The following is a description of a gene set: Human Gene Set: GOBP_NEGATIVE_REGULATION_OF_FAT_CELL_DIFFERENTIATION studied in species Homo sapiens Any process that stops, prevents, or reduces the frequency, rate or extent of adipocyte differentiation., and this is the list of marker genes: MIR107, RUNX1T1, WNT3A, SORT1, FERMT2, TRIB2, WNT5A, CCN4, MIR128-1, MIR448, WWTR1, TRIO, ADIPOQ, WNT1, MIR483, ANKRD26, FLCN, FOXO1, JDP2, MIR548D1, JAG1, YAP1, TNF, ASXL1, SMAD3, INSIG1, ID4, SLC7A10, TRIB3, C1QL4, SIRT2, DDIT3, ENPP1, RORA, WNT10B, TGFB1, CCDC85B, MIR27B, SIRT1, BMAL1, VEGFA, ZFP36L2, PTGR3, MMP11, MIR27A, E2F1, GPER1, TGFB1I1, MSX2, SOD2, TRPV4, GATA2, TLCD3B, AXIN1, BMP2, GPS2, ZFPM2, LRP3, IL6, MIR138-1, MIR103A1, BBS12